The following is a description of a gene set: from publication Pyeon D, Newton MA, Lambert PF, den Boon JA, Sengupta S, Marsit CJ, Woodworth CD, Connor JP, Haugen TH, Smith EM, Kelsey KT, Turek LP, Ahlquist P (PMID 17510386) Down-regulated genes in cervical carcinoma and head and neck tumors positive for human papilloma virus (HPV) compared to those negative for HPV. Human papillomaviruses (HPV) are associated with nearly all cervical cancers, 20% to 30% of head and neck cancers (HNC), and other cancers. Because HNCs also arise in HPV-negative patients, this type of cancer provides unique opportunities to define similarities and differences of HPV-positive versus HPV-negative cancers arising in the same tissue. Here, we describe genome-wide expression profiling of 84 HNCs, cervical cancers, and site-matched normal epithelial samples in which we used laser capture microdissection to enrich samples for tumor-derived versus normal epithelial cells. This analysis revealed that HPV(+) HNCs and cervical cancers differed in their patterns of gene expression yet shared many changes compared with HPV(-) HNCs. Some of these shared changes were predicted, but many others were not. Notably, HPV(+) HNCs and cervical cancers were found to be up-regulated in their expression of a distinct and larger subset of cell cycle genes than that observed in HPV(-) HNC. Moreover, HPV(+) cancers overexpressed testis-specific genes that are normally expressed only in meiotic cells. Many, although not all, of the hallmark differences between HPV(+) HNC and HPV(-) HNC were a direct consequence of HPV and in particular the viral E6 and E7 oncogenes. This included a novel association of HPV oncogenes with testis-specific gene expression. These findings in primary human tumors provide novel biomarkers for early detection of HPV(+) and HPV(-) cancers, and emphasize the potential value of targeting E6 and E7 function, alone or combined with radiation and/or traditional chemotherapy, in the treatment of HPV(+) cancers. species: Homo sapiens Human Gene Set: PYEON_HPV_POSITIVE_TUMORS_DN, and this is the list of marker genes: CTTN, FAM89A, CCND1, KRTDAP, NAP1L2, KLK10, CAV1, PTHLH, DEFB4A, KLK8